The following is a description of a gene set: Genes predicted to be targets of miRBase v22 microRNA hsa-miR-7112-3p in miRDB v6.0 with MirTarget v4 prediction scores > 80 (high confidence targets). Human Gene Set: MIR7112_3P from publication Chen Y, Wang X (PMID 31504780) studied in species Homo sapiens, and this is the list of marker genes: SH3KBP1, SF3B1, PPP6R2 (NCBI Gene Id 9701), MSL2, RPEL1, SLC36A2, FAM8A1, TSPYL2, RAB11FIP2, GLIPR2, XPO4, PLCB4, ZNF254, SLC16A9, PGBD5, ABCC2, PPM1A, FKBP1B, RRAGB, PAPOLA, ONECUT2, NDP, ESM1, FGF12, BEGAIN, UBAC2, PBX3 (PBX homeobox 3), KRTAP22-2, RNF182, DHRS13, NAV2, CALB2, ST6GALNAC3, PPM1H, ZDHHC17, TRIM39, SALL1, CCAR1, KAT6A, FAT1, SURF4, BTBD10, EPC1, PDIK1L, NFX1, SLC35F1, H2AZ1 (NCBI Gene Id 3015), TMEM26, RPE, MET, DDX28, AGO4, RBM46, TRHDE (thyrotropin releasing hormone degrading enzyme), HES1, BLTP3A, APCDD1, BEND6, TOX3, TMEM30A, GABPB1, MAP1B, RANBP6, CNOT6, PPHLN1, TAT (tyrosine aminotransferase), KLHL2 (kelch like family member 2), CBFB, CAMK2D, TMPRSS3 (NCBI Gene Id 93657), YWHAE, ST8SIA4, ANO4, CDH8, BCL2L11, RPGRIP1L, PABPC5, LRPPRC, ELAVL4, UBE3A, ATP2A2, IRAK4, TRIL, CSPP1, CALCB, SLC24A4, ZFP90, RRAGD, ENTPD1, DR1, ZEB2, TFDP2, RXRG, UGT2B10, MYT1